Given this list of marker genes GOT1, ADSS2, SLC38A8, GOT1L1, DDO, ADSS1, ASS1, ASPA, GOT2, here is a description of the gene set: Human Gene Set: GOBP_ASPARTATE_METABOLIC_PROCESS species: Homo sapiens The chemical reactions and pathways involving aspartate, the anion derived from aspartic acid, 2-aminobutanedioic acid.